Given this list of marker genes CCL19, CCL5, IL23A, PTPRJ, CSF1, CXCL8, DNM1L, EDN1, MSTN, RAC1, CCL21, MDK (midkine), MCU, C5AR2, TNFAIP6, CXCL17, C3AR1, MPP1, THBS4 (thrombospondin 4, NCBI Gene Id 7060), CSF1R, CCR7, JAM3, RIPOR2, C5AR1, PTK2, XCL1, CAMK1D, RARRES2 (NCBI Gene Id 5919), IL34, BST1, DAPK2, MAPK1, LBP, CMKLR1, DPP4, C1QBP, AKIRIN1, PERP, CCL2, MIR223, S100A7, MAPK3, S100A14, SLAMF1, TRPV4, SLIT2, MOSPD2, NCKAP1L, THBS1, RAC2, CD74, TNFSF18, TIRAP, here is a description of the gene set: species: Homo sapiens Any process that modulates the rate, frequency or extent of granulocyte chemotaxis. Granulocyte chemotaxis is the movement of a granulocyte in response to an external stimulus. Human Gene Set: GOBP_REGULATION_OF_GRANULOCYTE_CHEMOTAXIS